The following is a description of a gene set: Human Gene Set: chr5p15 species: Homo sapiens, and this is the list of marker genes: MARCHF11, ENSG00000249865, RNU1-76P, LPCAT1 (NCBI Gene Id 79888), ANKRD33B-AS1, H3P17, ENSG00000288978, CLPTM1L, MTCO2P32, ADCY2, CFAP90, LINC02236, UBE2QL1, LINC02226, CEP72-DT, ENSG00000302231, EEF1A1P13, SPICP4, LSINCT5, ANKH-DT, RN7SKP79, ENSG00000288930, IRX4 (NCBI Gene Id 50805), ENSG00000297585, TENT4A, ENSG00000248973, ANKH, PPP4R2P1, DCAF13P2, CCT5, MTCO1P31, MIR6075, IRX2, MED10, RNA5SP178, MIR4457, MARCHF6-DT, TAF11L5, SLC9A3-AS1, IRX1, ATPSCKMT, MIR4637, RNU6-1003P (NCBI Gene Id 106481778), FBXL7 (F-box and leucine rich repeat protein 7), RNA5SP180, RPL30P7, IRX2-DT, BASP1, ZDHHC11B, LINC01019, SEMA5A-AS1, TAF11L13, SRD5A1, TAF11L8, CTD-2194D22.4, TAF11L11, RN7SKP73, TAS2R1, HNRNPKP5, MIR6131, MIR4636, LINC01018, MTCO2P30, OTULIN-DT, LINC02199, H3P22, RNA5SP176, UQCRBP3, ENSG00000286753, TAF11L3, BRD9P2, RPS23P5, PPP4R2P5, RPS26P28, TRIP13, SNORD81, ENSG00000286441, LINC02217, MTRR, LINC02123, RNA5SP177, ZDHHC11, ENSG00000248994, CTNND2, MARCHF11-AS1, RNU6-429P, RNU6-679P, TAF11L9, TPPP, LINC03067, MTCO1P30, RETREG1-AS1, LINC02220, SLC6A3, H3Y1, PDCD6P1, IRX4-AS1, NKD2, LINC02149, PDCD6-DT (NCBI Gene Id 102467073), H3P21 (H3 histone pseudogene 21), MARCHF6, RPL29P13, SEMA5A, LINC02223, DAP, MIR4458 (NCBI Gene Id 100616142), LINC01511, NDUFS6, SEPHS2P1, MYO10 (myosin X), ENSG00000260763, HMGB3P3, MARCHF11-DT, ENSG00000286377, TAF11L4, OTULIN, CCT6P2, TRIO, LINC02162 (NCBI Gene Id 105374624), LINC02112, LINC02218, EXOC3-AS1, CCDC127, H3P20, ADAMTS16-DT, ENSG00000202269, TAF11L6, FTH1P10, MIR4278, LINC02102, MIR4635, TERLR1, EXOC3, NENFP3, TAF11L14, LINC02114, SDHAP3, BRD9, RNU6-660P, SLC9A3, RN7SKP133, ADAMTS16, TERT, LINC02982, TAF11L12, LRRC14B, AHRR, MIR4458HG, OTULINL, TAF11L7, LINC02063, RNA5SP179, LINC02212, LINC02221, SNHG18, LINC02145, ZNF622, DAP-DT, RBBP4P1 (RBBP4 pseudogene 1), LINC02213 (NCBI Gene Id 389273), ROPN1L-AS1, NSUN2, FASTKD3, MTCYBP37, BASP1-AS1, PDCD6-AHRR, CMBL, LINC02196, LINC02111, PLEKHG4B, ENSG00000248783, PDCD6, MTND6P2, LINC01194, LINC02116, SLC9A3-OT1, MRPL36, LINC01020, SLC6A19, SPCS2P3, MARK2P5, ENSG00000303091, LINC01377, MIR4456 (microRNA 4456), SLC6A18, RETREG1, SNORD123, DNAH5, H3Y2, MIR887, RPL36AP21, H3P19, TAF11L10, CEP72, SLC12A7, LINC02142, SDHA, MIR4277, ENSG00000249782, ICE1, ALG3P1, LINC02121, NACAP6, ANKRD33B, TAF11L2, H3P18, ROPN1L, LINC02150